The following is a description of a gene set: Mouse Gene Set: GOBP_GOLGI_DISASSEMBLY A cellular process that results in the breakdown of a Golgi apparatus that contributes to Golgi inheritance. studied in species Mus musculus, and this is the list of marker genes: Golga2, Stx5a, Cdk1, Vrk1, Plk3, Gbf1